The following is a description of a gene set: studied in species Homo sapiens Human Gene Set: HP_OSTEOLYSIS_INVOLVING_BONES_OF_THE_FEET Osteolysis involving bones of the feet, and this is the list of marker genes: MMP2 (NCBI Gene Id 4313), ASAH1, MAFB (NCBI Gene Id 9935), WNK1, NOTCH2, SCN9A (NCBI Gene Id 93955), ZMPSTE24, COL3A1, MMP14, KIF1A, RETREG1, LMNA